The following is a description of a gene set: Mouse Gene Set: MIR_132_3P from publication Chen Y, Wang X (PMID 31504780) Genes predicted to be targets of miRBase v22 microRNA mmu_miR_132_3p in miRDB v6.0 with MirTarget v4 prediction scores > 80 (high confidence targets). species: Mus musculus, and this is the list of marker genes: Eif1b, Ark2n, Lipm, Tti2, Dusp9, Fam167a, Mycbp2, Lrrfip1, Lin28b, Ube2d2a, Cldn10, Atxn1, Dnajb14, Nras, Tmeff1, Acvr2b, Gdf5, Klf17, Scn7a, Tmem164, Mef2a, Med9, Nova1, Slc17a2, Polr2d, Rictor, Pcdh10, Nrep (neuronal regeneration related protein), Fam91a1, Kcna6, Larp4, Shh, Gpatch2l, Fam3c, Foxo3, Rlim, Mideas, Eloc, Tbc1d30, Grhl2, Lemd3, Zbed5, Tln2, Nin, Stx16, Timm9, Lmnb2, Ccdc71l, Ptbp2, Chd1, Kif26a, Mapk1, Nfatc2, Cc2d1b, Hmga2, Sox5, Ttc14, Lsm11, Rbak, Nlk, Dnmt3a, Rad54l2, Mme, Cyp2e1, Dazap2, Pspc1, Dcun1d4, Osbpl8, Pdzrn4, Glcci1, Pramel4, Dhx37, Pigs, Adgre4, Rgs7bp, Kdm7a, Dpysl3, Cfap36, Zfp516, Ehhadh, Tut4 (NCBI Gene Id 320841), G3bp2, Zfyve1, Bri3, Slc6a1, Btc, Pdp2, Hapln1, Pramel5, Melk, Zdhhc20, Cnot10, Hbegf, Calu, Klhl11 (NCBI Gene Id 217194), Ssh2, Phka1, Daam1, Nacc2, Emc1, Mrpl20, Chmp3, Psip1, Slco1a1, Sgk3, Pom121, Ppp2r5e, Ep300, Rras2, Sema6a, Brwd1, Klhl15, Tjap1, Prss46, Adamts5, Dixdc1, Thsd7a, Bclaf1, Sall1, Rasa1, Magee2, Foxp2 (forkhead box P2), Pnn, Med28, Pramel61 (NCBI Gene Id 545696), Mex3c (mex3 RNA binding family member C), Timd5, Atp23, Garem1, Usp9x, Mia3, Zfp874b, Zfp236, Twist1, Tmem161b, Sppl3, Cbll1